Given this list of marker genes Calm1, Ppp3r1, Fkbp1a, here is a description of the gene set: studied in species Mus musculus electronically inferred by orthology from the curated human pathway This event has been computationally inferred from an event that has been demonstrated in another species.<p>The inference is based on the homology mapping from PANTHER. Briefly, reactions for which all involved PhysicalEntities (in input, output and catalyst) have a mapped orthologue/paralogue (for complexes at least 75% of components must have a mapping) are inferred to the other species. Reactome Pathway: Calcineurin activates NFAT part of: Downstream signaling events of B Cell Receptor (BCR)